The following is a description of a gene set: Any process that activates or increases the frequency, rate or extent of amyloid fibril formation. species: Homo sapiens Human Gene Set: GOBP_POSITIVE_REGULATION_OF_AMYLOID_FIBRIL_FORMATION, and this is the list of marker genes: APP, CLU, USP8, APOE (apolipoprotein E), PSEN1